The following is a description of a gene set: from publication Johnstone CN, Mongroo PS, Rich AS, Schupp M, Bowser MJ, Delemos AS, Tobias JW, Liu Y, Hannigan GE, Rustgi AK (PMID 17998334) Genes down-regulated upon overexpression of PARVB in MDA-MB-231 cells (breast cancer) cultured in 3D collagen I and 3D Matrigel only. studied in species Homo sapiens Human Gene Set: JOHNSTONE_PARVB_TARGETS_2_DN Parvin-beta is a focal adhesion protein downregulated in human breast cancer cells. Loss of Parvin-beta contributes to increased integrin-linked kinase activity, cell-matrix adhesion, and invasion through the extracellular matrix in vitro. The effect of ectopic Parvin-beta expression on the transcriptional profile of MDA-MB-231 breast cancer cells, which normally do not express Parvin-beta, was evaluated. Particular emphasis was placed upon propagating MDA-MB-231 breast cancer cells in three-dimensional culture matrices. Interestingly, Parvin-beta reexpression in MDA-MB-231 cells increased the mRNA expression, serine 82 phosphorylation (mediated by CDK9), and activity of the nuclear hormone receptor peroxisome proliferator-activated receptor gamma (PPARgamma), and there was a concomitant increase in lipogenic gene expression as a downstream effector of PPARgamma. Importantly, Parvin-beta suppressed breast cancer growth in vivo, with associated decreased proliferation. These data suggest that Parvin-beta might influence breast cancer progression., and this is the list of marker genes: IRS1, TRIB2, OARD1, HADH, RBBP4, PPP3CA, ZNG1A (Zn regulated GTPase metalloprotein activator 1A), C1GALT1, AKIRIN1, ELOVL5, RUNX2, SHISA2, MCUR1, CUL5, PTAR1, ANKRD13C, CRYZ, SNHG33, PNRC2, CAP2, RIN2, EPM2AIP1, RNF19A, ZNF468, SEC22B, GTF2A1, RO60, TGFBR1, STMP1, CILK1, OPA1, HYCC1, TMEM65, BICRAL, DCUN1D4, PPP2R5E, PDGFC (platelet derived growth factor C), LEPR, PPA2, C8orf33, ZDHHC2, DPYD, STAG1, SSBP2, SFPQ, DHX15, VPS13A, HNRNPLL, AIRIM, ASPH, DCUN1D1, NUP153, TMEM165, SLC25A40, SEC24B, UTP11 (UTP11 small subunit processome component), HSPA1A, UBTD2, WIPF1, PSMB2, GBE1, EXOC5, DYNLT2B (dynein light chain Tctex-type 2B), ATP5IF1, FRG1CP, PPP2R5C, SRPK1, NUP62 (NCBI Gene Id 51551), NUDT21 (nudix hydrolase 21), CCN2, SLC35A1 (NCBI Gene Id 10559), GMDS, ECI2, WAC-AS1, ATP11B, HNRNPR, DEF6, ETNK1 (ethanolamine kinase 1), MAP2, HOOK3, BTC, RRP36, CASP3, RAB28, TMTC3, SMIM13, RCN2 (reticulocalbin 2), B3GNT5, ESD (NCBI Gene Id 2098), MBNL1, FIGN, UBR2, RASA2, LIN7C, ANGPT1, ATP5ME, PDZD8, TMEM128, OSBPL8, MYCBP2, CDYL, NFYA, RASSF8, PGBD1, SEPHS1, NR2F1-AS1, LEMD3, POPDC3, CREM, RBM26, STK17A, RFX7, GLCE, MOB1B, SCML1, CNIH1, GLUD1, S100PBP (NCBI Gene Id 64766), SLC30A5, AHRR, IFRD1, RBMS3, EMP1, COMMD5, ISOC1, PFN2, NMRAL1, CAMK2D, ATF1, CENPQ, SGPL1, STK17B, SLC44A1, MRS2, PLPP3, NR3C1, MMUT, DCP2, MAPK14, TRERF1, FAF1, GLS, RREB1, GXYLT1, LNPK, SHOX2, MIR3648-1, MDC1, CYC1, MRPL14, PRIM2, PHC3, ABCC10, ZNF532, ENPP1, UFL1, NOL7, PPWD1, WRNIP1, PDGFA, HIPK1, CDK13, RCHY1, E2F3, TMEM14A, MIS18BP1, UBE3A, ENSG00000269825, PCNP, KIF13A, UCHL5, C6orf62, ZMYM1, TMPO, NFX1, MED4 (mediator complex subunit 4), ALCAM, SLC16A7, FUBP1, HIVEP3, TTC39C, SRD5A1, PRP4K, CSNK1A1, DACH1, TDP2, PDIK1L, PAK1IP1, SLK, IPO5, USP4 (NCBI Gene Id 7375), PPIL1, BACE2, TNFRSF21, GORAB, PRPF39, TCERG1, TMEM14C, ARL5A, USP34, HNRNPA3, RAP2C, SRRM1, NBPF9, RBFOX2 (NCBI Gene Id 23543), TBL1XR1, CDC5L, TMEM14B, TCAF1, ZNF623, SYNJ2BP, DST, PPM1A, TSPAN5, POLR1C, SRSF4, AGFG1, GCNT2, CHML, RAP2B, TM9SF3, TPT1-AS1, TPST1, DSEL, TAF2, CASP1, SNRNP48, SSR1, KPNA6, FRMD6, NUFIP2, PRPF31 (pre-mRNA processing factor 31), SLC31A1, ZNF184, ERO1A, CDK6, TOMM6, TECR, EFNA5, SRSF1, WEE1, SLC39A8, PRKCA, FIRRM, DDAH2, GULP1, TNFAIP8, ZNF83, TMEM33, CST7, FOXJ3, SESTD1, ZNF654, HS3ST3B1, SLC38A4, F2R, TAF11, SLC35B3, AXIN2, SPRY1, COLGALT1, CPE, SNHG32, MSRB3, MAGT1, MANEA, CUTA, PLEKHA5 (pleckstrin homology domain containing A5), ARHGEF10, ARPP19, B3GALNT1, KCTD20, CYB5A, LRP6, NUP58, HSPA4, LHFPL6, CLIC4, ADO, CHASERR, TOMM20, ARRDC3, MRPS10, MCM3, SYNCRIP, UBE2G1, SOAT1 (sterol O-acyltransferase 1), POLH, SMC3, RHOJ, DOCK4, NADK2, FSD1L, FBXO9, ZFYVE28, ATP2C1, EHBP1, RDH13, DOCK9, NECTIN3, SRSF3, DERA, RBPJ, CPNE8, TOP2B, CTBP2, NET1, USP46 (NCBI Gene Id 64854), CBX5, SRGN, PTPRG, SOCS5, ADM, PTP4A2, PTK2, BPNT2, SRSF10, SLC5A3, LIMCH1, GALNT7, FXR1, MYLK (myosin light chain kinase, NCBI Gene Id 50483), BLOC1S5, ENPP4, ZMPSTE24, TRAM2, CCDC126, F2RL1, SMURF2, RANBP9, XRN1, MRPS18B, ZKSCAN8, LINC01505, RUNDC3B, ZNF814, NQO2, OGFOD3, AGTPBP1, RIOK1, AK2, HDAC1, PARVA, OXR1